Given this list of marker genes Pdpk1 (NCBI Gene Id 18607), Gng5, Gng8, Gnb2, Gng3, Gng11 (guanine nucleotide binding protein (G protein), gamma 11), Gnb5, Gng10, Gng7, Gngt2, Gngt1, Gnb3, Pik3r5, Gng4, here is a description of the gene set: species: Mus musculus Reactome Pathway: G beta:gamma signalling through PI3Kgamma electronically inferred by orthology from the curated human pathway This event has been computationally inferred from an event that has been demonstrated in another species.<p>The inference is based on the homology mapping from PANTHER. Briefly, reactions for which all involved PhysicalEntities (in input, output and catalyst) have a mapped orthologue/paralogue (for complexes at least 75% of components must have a mapping) are inferred to the other species. part of: G-protein beta:gamma signalling